The following is a description of a gene set: Reactome Pathway: Regulation of mRNA stability by proteins that bind AU-rich elements RNA elements rich in adenine and uracil residues (AU-rich elements) bind specific proteins which either target the RNA for degradation or, more rarely, stabilize the RNA. The activity of the AU-element binding proteins is regulated, usually by phosphorylation but also by subcellular localization. species: Homo sapiens part of: Metabolism of RNA, and this is the list of marker genes: MAPKAPK2, TNFSF13, PSMA5, HSPA1A, AKT1, PSMA1, ADRM1, PABPC1, EXOSC2, PSMB5, GPRC5A (NCBI Gene Id 9052), MAPK14, PSMD13, PSMD8, PSMC3, YWHAZ, SEM1, HNRNPD, ANP32A, PSMC5 (proteasome 26S subunit, ATPase 5), EXOSC7, YWHAB, ZFP36L1, EXOSC4, TNPO1, PSMA6, UBC, DIS3, EXOSC6, PSMB3, PSMA3, EXOSC8, PARN, ENPP2, PSMC2, PRKCA, XPO1, HSPA8, NUP214, PSMB6, PRKCD (NCBI Gene Id 5580), PSMD7 (NCBI Gene Id 5713), EXOSC9, PSMA7 (proteasome 20S subunit alpha 7), HSPB1, PSMB4, ELAVL1, EXOSC3 (NCBI Gene Id 51010), EXOSC5, DCP1A, KHSRP, PSMD2, PSMC6, PSMD1, PSMA4, UBB, SET, PSMB2, ZFP36, PSMA2, PSMC1, MAPK11, XRN1, RPS27A, EIF4G1, PSMB7, PSMB1, PSMD3, PSMD11, DCP2, PSMC4, PSMD14, PSMD12, PSMD6, EXOSC1, UBA52